The following is a description of a gene set: Glycosaminoglycan biosynthesis, linkage tetrasaccharide. Pathway ID: N01574. Pathway type: Reference. Pathway class: nt06029 Glycosaminoglycan biosynthesis. Pathway Definition from KEGG: Protein-Ser -- XYLT1/2 >> B4GALT7 >> B3GALT6 >> -> G00157 species: Homo sapiens Human Gene Set: KEGG_MEDICUS_REFERENCE_GLYCOSAMINOGLYCAN_BIOSYNTHESIS_LINKAGE_TETRASACCHARIDE, and this is the list of marker genes: XYLT1, B4GALT7, B3GALT6, XYLT2 (xylosyltransferase 2), B3GAT3 (NCBI Gene Id 26229)